The following is a description of a gene set: GPVI-mediated activation cascade Mouse Gene Set: REACTOME_GPVI_MEDIATED_ACTIVATION_CASCADE studied in species Mus musculus, and this is the list of marker genes: Syk, Mpig6b, Pik3r3, Pik3cg, Plcg2, Pik3r2, Vav1, Vav3, Ptpn6, Gp6, Fcer1g, Pdpn, Pik3r5, Pik3r1, Rhob, Cdc42, Rhoa, Rac2, Pdpk1, Lck, Rac1, Fyn, Pik3r6, Lat, Col1a2, Pik3ca, Clec1b, Pik3cb, Col1a1, Lyn, Vav2, Ptpn11, Rhog, Lcp2